Given this list of marker genes IKBKB, TICAM1, NKIRAS1, CHUK, NKIRAS2, MYD88, NFKB2, TLR3, RIPK1, NFKBIA, RIPK3, RELA, DHX9, ZBP1, NFKB1, NFKBIB, IKBKG, here is a description of the gene set: RIP-mediated NFkB activation via ZBP1 Human Gene Set: REACTOME_RIP_MEDIATED_NFKB_ACTIVATION_VIA_ZBP1 studied in species Homo sapiens